The following is a description of a gene set: Estrogens are a class of hormones that play a role in physiological processes such as development, reproduction, metabolism of liver, fat and bone, and neuronal and cardiovascular function. Estrogens bind estrogen receptors, members of the nuclear receptor superfamily. Ligand-bound estrogen receptors act as nuclear transcription factors to regulate expression of genes that control cellular proliferation and differentiation, among other processes, but also play a non-genomic role in rapid signaling from the plasma membrane. Reactome Pathway: ESR-mediated signaling part of: Signaling by Nuclear Receptors species: Homo sapiens, and this is the list of marker genes: PIK3R3, H3C1, CBFB, KPNA2, RAD21, H2AC18, PPID, CREB1, MAPK1, GNGT1, SRF, PRMT1, ATF2, KAT2B, NCOA3, BTC, MAPK3, H2AC4, CARM1, H2BC5, GREB1, STAG1, AREG, EGF, MIR26A1, TFF3, NRAS, EBAG9, POLR2C, TNRC6A, GNG8, EPGN, ZDHHC7, TBP (TATA-box binding protein), H2BC14, MMP3 (NCBI Gene Id 4314), TNRC6B, BCL2, GNB3, GNG13, H2AC7, MIR26A2, GNB5, GNB4, AGO3, TLE3, KAT5, ERBB4, GNG2, ZNF217, TNRC6C, H4C1, JUND, S1PR3, HSP90AB1, EP300, IGF1R, USF2, POLR2E, MMP7, GNAT3 (G protein subunit alpha transducin 3), ESR1, AGO4, AGO1, PTGES3, MYB, POLR2J, H2AC14, PIK3CA, CAV1, H2AC20, SMC3, YY1, GNAI2, NCOA2, RUNX1, POLR2I, H2BC4, MED1, EGFR, H2BC13, NCOA1, DDX5, FKBP5, CTSD, CHD1, KCTD6, ZDHHC21, FKBP4, FOXO3, HSPB1, POLR2A, PTK2, AKT3, JUN, XPO1, CITED1, H2BC17, TGFA, GNAI1, PDPK1, H2BC12, H2BC9, CAV2, ESR2, H2BC21 (NCBI Gene Id 8349), KDM1A, SHC1, GTF2F1, GTF2F2, POLR2K, CCND1, MIR26B, H2AB1, GNG5, AGO2, CDKN1B, SP1, GNAI3, ELK1, STRN, H2BC1, H2AX, KDM4B, H2BC11, PIK3R2, GPAM, CXXC5, PGR, CREBBP, H2BC12L, POLR2L, HDAC1, NOS3, POLR2F, STAG2, GNG4, POLR2H (NCBI Gene Id 5437), MOV10 (NCBI Gene Id 57723), UHMK1, POLR2G, CCNT1, GNGT2 (G protein subunit gamma transducin 2), KRAS, EREG, MMP2, CALM1, GNG12, GTF2A1, KANK1, POU2F1, GNG3, AXIN1, H3-3A, POLR2D, CDK9, MYC, GNG10, H2BC15, H2AZ2, GATA3, PRKCZ, AKT2, SRC, H2BC26, H2AC6, HBEGF, NRIP1, PIK3R1, SMC1A, SPHK1, GNB2, POLR2B, H2BC3, PPP5C, MMP9, AKT1, CXCL12, GNG7, USF1, GNG11, H3C15 (NCBI Gene Id 449003), HRAS, H2AJ, TFF1, NR5A2, FOSB (NCBI Gene Id 2354), FOS, GNB1, HSP90AA1, GTF2A2, FOXA1